Given this list of marker genes LEO1, GPR68 (NCBI Gene Id 8111), RCOR1, ZNF675, GATA2, ACVR1B, TREM2, GPR171, HSPA1A, STAT5B, HAX1, LTF, INHBA, FSHB, PURB, NFKBIA, DLL1, TNF, GABPA, APCS, THPO, LRRC17, CDK6, HIF1A, H4C5, JAG1, MIR145, HOXA7, ACVR2A, TNFRSF11B, CREB1, RAB7B, FOS, MEIS1, H4C9, POU4F2, ARNT, H4C12, ZNF16, PAF1, P4HTM, IL4, HLA-DRB1, FBXW7, PF4, IL12B, YPEL4, IL17A, MIR223, RHEX, ANKRD54, ID2, PIAS3, TESC, CALCA, ZFP36L1, NOTCH2, RIPK1, FAXDC2, IRF7 (interferon regulatory factor 7), STAT5A, OCSTAMP, PLA2G3, KITLG, MIR222, CTNNBIP1, TMEM178A, CASP8, SLC9B2, CNOT4, KAT7, NEDD9, MTOR, IL23A, HSPA1B, H4C15, IL5, H4C1, BGLAP, RNF41, GATA1, H4C3, ITPKB, LYN, TCTA, SPI1, ZFP36, H4C13, GPR137B, MYB, PRMT1, FES, EEIG1, CLDN18, RBM15, C1QC, CSF1, FAM210B, CEACAM1, RPTOR, TLR3, SKIC8, FOXP1, IL20, MIR221, TOB2, MED1, HCLS1, SMAP1, LILRB1, QKI, PRKDC, CUL4A, MEF2C, TNFRSF11A, IL34, CCR1, B2M, HMGB2, LOX, FSHR, PRXL2A (NCBI Gene Id 84293), RARA, GPR55, CEBPB, CTNNB1, GLUL, TGFB1, LILRB3, MAFB, RASSF2, HMGB1, FADD, LILRB4, FOXO3, SCIN, TLR4, TRIB1, HOXA5, INPP5D (inositol polyphosphate-5-phosphatase D), PTK2B, EIF6, ZBTB46, KLF10, CARTPT, RB1, ETS1, PRDM16, CIB1, POU4F1, HSPA9, H4C2, PRKCA, H4C14, TYROBP, MAPK11, CD4, ADIPOQ, H4C11, GPR137, H4C16, RUNX1, STAT1, NDFIP1, ACIN1, NCKAP1L, LIF, CCL3, ZBTB16, HSF1, CAMK4, TNFAIP6, LDB1, ZFPM1, PTPN2, LEF1, MYC, CTR9, TRAF6, STAT3, MEIS2, NF1, ABCB10, MIR486-1, MITF, RARG, MIR125B1, HOXB8, DCSTAMP, TNFSF11, KLF13, EVI2B, ISG15, CD101, TAOK3, MTURN, TMEM64, H4C8, PRMT6 (NCBI Gene Id 55170), CD74, PIK3R1, HMGB3, CSF3, UBASH3B, CDC73, MPL, FBN1, CSF3R, FSTL3, L3MBTL1, IL23R (interleukin 23 receptor), TM4SF19, PPARGC1B, SENP1, PITHD1, ERFE, SFRP1, TAL1, INHA, IFNG, MAPK14, HOXA9, H4C4, BRD1, H4C6, TFE3, PPP3CA, IAPP, here is a description of the gene set: studied in species Homo sapiens Human Gene Set: GOBP_REGULATION_OF_MYELOID_CELL_DIFFERENTIATION Any process that modulates the frequency, rate or extent of myeloid cell differentiation.